The following is a description of a gene set: studied in species Homo sapiens The transcription factor FoxP3 partakes dominantly in the specification and function of FoxP3+ CD4+ T regulatory cells (Tregs), but is neither strictly necessary nor sufficient to determine the characteristic Treg transcriptional signature. Computational network inference and experimental testing assessed the contribution of several other transcription factors (TFs). Enforced expression of Helios or Xbp1 elicited specific signatures, but Eos, Irf4, Satb1, Lef1 and Gata1 elicited exactly the same outcome, synergizing with FoxP3 to activate most of the Treg signature, including key TFs, and enhancing FoxP3 occupancy at its genomic targets. Conversely, the Treg signature was robust to inactivation of any single cofactor. A redundant genetic switch thus locks-in the Treg phenotype, a model which accounts for several aspects of Treg physiology, differentiation and stability. Human Gene Set: GSE40274_CTRL_VS_FOXP3_AND_GATA1_TRANSDUCED_ACTIVATED_CD4_TCELL_UP from publication Fu W, Ergun A, Lu T, Hill JA, Haxhinasto S, Fassett MS, Gazit R, Adoro S, Glimcher L, Chan S, Kastner P, Rossi D, Collins JJ, Mathis D, Benoist C (PMID 22961053) Genes up-regulated in CD4 T conv: control versus over-expression of GATA1 and FOXP3., and this is the list of marker genes: S100A11, HSPA1A, MIR490, MIR20B, ZBTB8A, TOX, IL12RB2, SERPINB10, PNRC2, CCL5, ENPP2, NRP1, TNFRSF17, CALM1, CD226, PDGFB, HSD11B1, MEX3B, CST7, SDC1, NR3C2, GZMB, RAB11FIP3, TNFSF8, CHST2, CRIM1 (NCBI Gene Id 51232), HP, WHRN, SERPINA6, FZD4, RAB5A, KCNE3, SNORA2C, NONO, RPS6KA1, KCNIP3, PCP4, CARD9, S100A10, FAS, SEC11C, EVX2, NT5E, PTCHD1, ABTB3, RAP1A (NCBI Gene Id 5906), TYROBP, TRAFD1, ADORA2A, SRGAP3, CHRDL1, CD96, GAS6, MCUB, LY86, CDK9, CLNK, STYK1, PIK3R3, PHC2, S100A6, PLEKHG1, ARPC2 (actin related protein 2/3 complex subunit 2), CNGA1, PLCD3, XDH, ARPC5, MAP1LC3B, RTL5, KLRC1, EAF2, SSU72, NME2, CHMP2B, DCTN1, ANXA2, EPSTI1, COL14A1, SPN, RAMP1, MFSD2A, KLRC3, CCR2, PHGDH, ITK, ITGA2, NIBAN2, KRT80, TBX21, ALCAM, PRLR, MEFV, NUMBL, TSC22D3, EED, LRRTM1, EHF, PON3, TRAF1, ORMDL1, IL18R1, SERF2, KCTD11, HYOU1, GRK4, FXYD5, CD7, TUBB2B, TMEM14A, SMPDL3A, MSI2, MUC3A, RPL5, SLPI, CD79A (NCBI Gene Id 973), HK3, KLHDC4, ADGRA2, VPS28, SFMBT2, RALA, PILRA, GPN2, BMP2, TNFSF18, RARG, P4HA1, RASAL1, HAP1, COQ10B, HSPH1, SNN (stannin), SNORA2B, CD3D, PROCA1, TMSB4X, ATP1B1, ASPRV1, PCTP, RSRC2, TDRD6